The following is a description of a gene set: species: Mus musculus The chemical reactions and pathways involving tetrahydrobiopterin, the reduced form of biopterin (2-amino-4-hydroxy-6-(1,2-dihydroxypropyl)-pteridine). It functions as a hydroxylation coenzyme, e.g. in the conversion of phenylalanine to tyrosine. Mouse Gene Set: GOBP_TETRAHYDROBIOPTERIN_METABOLIC_PROCESS, and this is the list of marker genes: Dhfr, Pcbd1, Pts, Spr, Gch1, Pcbd2, Qdpr